The following is a description of a gene set: Mouse Gene Set: GOBP_LEUKOTRIENE_TRANSPORT species: Mus musculus The directed movement of leukotrienes into, out of or within a cell, or between cells, by means of some agent such as a transporter or pore. Leukotrienes are linear C20 endogenous metabolites of arachidonic acid (icosa-5,8,11,14-tetraenoic acid) containing a terminal carboxy function and four or more double bonds (three or more of which are conjugated) as well as other functional groups., and this is the list of marker genes: Abcc3 (ATP-binding cassette, sub-family C member 3), Abcc4, Abcc6, Abcc1, Abcc10, Abcc2